Given this list of marker genes Retn, Nmu, Trh, Aim2, Mdk, Eif2ak4 (eukaryotic translation initiation factor 2 alpha kinase 4), Gja1, Npas2, Zfhx3 (NCBI Gene Id 68160), Stra6, Drd2, Penk, Mc4r, Ptger3, Agrp, Insl5, Oprl1, Casp1, Gria1, Rag1, Mtnr1b, Per3, Ptger4, Grpr, Insr, Hdac2, Ahi1, Npy2r, Stat3, Npy, Mef2c, Alb, Dlg4, Cfap20, Mbd5 (NCBI Gene Id 98951), Ins2, Lepr, Hcrtr2, Hdac4, Htr2b, Ada, Htr1d, Drd1, Dgat1, Oprk1, Cntnap4, Arrdc3, Ephb2, Fxr1, Cckbr (NCBI Gene Id 12426), Cort, Reln, Ttc21b, Drd3, Cck, Ucn, Gla, Mc1r, Esr2, Chrnb2, Mc3r, Kcna2, Nr1d1, Ghrl, Slc24a4, Ghrhr, Grp, Ghrh, Nrxn1, Fto, Mecp2, Pmch, Gpr171, Tacr3, Rxfp4, Crhr1, Cnr1, Vps35, Trpc2, Crhr2, Qrfp, Nlgn1, Htr1b, Baiap3, Mchr1, Sgip1, Ghsr, Esp22, Csf2, Npsr1, Crh (NCBI Gene Id 383938), Ptgds, Apoe, Hoxa1, Adora1, Uts2, Htr1a, Nr4a3, Mtor, Ankrd26, Dbn1, Ift88, Napepld, Shank3, Ins1, Nr2c2, Ceacam2, Nps, Adrb1, Uts2r, Adora2a, Il6, Parp1, here is a description of the gene set: species: Mus musculus Mouse Gene Set: GOBP_REGULATION_OF_BEHAVIOR Any process that modulates the frequency, rate or extent of behavior, the internally coordinated responses (actions or inactions) of whole living organisms (individuals or groups) to internal or external stimuli.